Given this list of marker genes Dcp2, here is a description of the gene set: This event has been computationally inferred from an event that has been demonstrated in another species.<p>The inference is based on the homology mapping from PANTHER. Briefly, reactions for which all involved PhysicalEntities (in input, output and catalyst) have a mapped orthologue/paralogue (for complexes at least 75% of components must have a mapping) are inferred to the other species. Reactome Pathway: KSRP (KHSRP) binds and destabilizes mRNA part of: Regulation of mRNA stability by proteins that bind AU-rich elements studied in species Mus musculus electronically inferred by orthology from the curated human pathway